Given this list of marker genes PIGM, RFX3, MAU2, AAR2, TRIM32, LYN, FBXL5, NT5E, MCC, TBC1D12, CDIPT, PI15, CLOCK, PRELID3B, SH3BP4, RTKN2, CREB1, UGT1A4, PAPPA, EMP2, MAP4, SKA1, GALNT18, HDAC9, MAFB, HSPE1, TCF7L2, RPS6KA6, NCK1, ADAM28, BBC3, STX18, CREBRF, FLVCR2, C3orf70, CMTM4, GOLPH3L, SYT9, PHIP, SESTD1, RD3L, BARD1, RICTOR, DLX3, NCKAP5, ADAMTS6, SLC5A3, HELB, TREM1, KIF3A, PLPPR4, DMKN, MXD1, DUSP16, FGG (NCBI Gene Id 2266), MAGEA8, ZNF706, MTCL2, RBM12, ZNF566, PABIR1, DIP2B, FAT4, TK2, ZNF699, SERPINB5, C3orf62, RAP1B, ENAH, ARHGEF11, FXYD6, CNOT6, ATP2B2, PPP1R1C, GPATCH2L, KIN, SGO1, SEMA3A, LAMC1, ALK, RIPOR3, H3-3B, RTP4, NEXMIF, A1CF, MAB21L1, NCL, ROCK2, TM9SF3, EVI5, UGT1A3, SNX13, RRAGB, SH3PXD2B, NREP, BCL2L2-PABPN1, MED13L, ADGRL2, UCK2, ARSJ, KLF12, GMFB, SDR16C5, GABRP, ZBTB14, EPHA5, YWHAQ, PARP9, AQR, MAGEA4, NAB1, MMD2, ZNF251, GATAD2B, CDK12, ABCA9 (ATP binding cassette subfamily A member 9), RBMS3, NFYC, CSTF2T, GAPVD1, SH3GLB2, KIF5B, USP37, UBE2H, RBM11, ZNF565, TIMELESS, PCDH19 (protocadherin 19), MOB1B, ALDH6A1, CAP1, SALL4, GRM3, CHST2, UTRN, MBOAT2, ACER3, DLG2, FBXL3 (F-box and leucine rich repeat protein 3), KDM2B (lysine demethylase 2B), SYTL4, HLF, MTX2, UGT1A8, MSI1, PIK3R3, ZBTB34, ZNF704, HOXA7, KLHL13, UNC5C, SSR3, ASH1L, SRR, KCNQ5, UGT1A9, ACO1, RPRD1A (NCBI Gene Id 55197), SLC7A14, LRCH1, CASD1, SRGAP3, LAMP3, NR3C1, TUB, GMCL1, GPR146, CLINT1, KLHL24, AHR, HIC2, SBSPON, NHLH2, TRMT10A, ATG2B, SEZ6, UGT1A6, NFAT5, ADAM22, SLC25A24, PREX1, MOB3B, MACO1, SHISA6, LRP2, SMAD2, SYT1, RFLNB, UBTF, PLCB4, RFPL1, MTFR2, SNX17, GPM6B, TATDN3, IQGAP2, KIF21A, UGT1A7, STEAP4, LRRTM4, UGT1A5, PGAP4, MME, FSTL1, SART3, CDKN1B, STARD13, TSPAN2, ALG6, ENOX1, RAB3GAP2, PAK3, PHF20L1 (PHD finger protein 20 like 1), ZNF148, MFAP1, FAM53A, PTBP3, ZZZ3, ZBTB41, VOPP1, TRPM7, PTPN14, GABRA1, ERLIN2, XPR1, TOX3, UNC79, PRLR, UGT1A10, TAS2R14, FDFT1, ZNF770, PRKACB, KCNA1, SLC30A4, PABPN1, MTO1, FZD6 (frizzled class receptor 6), GTF2H1, DCAF7, PFN2, HTR2B, RABL2A, MRPL43, NAV3, CTNNB1, GABRA6, PPFIA2, CUL4B, AIDA, CP, CELF2, PURA, GFRA1, SMYD2, KLHDC10, MS4A1, ASB7, ZNF750, PHYHIPL, HDAC4, MBNL1, CNBD2, TANC2, UGT1A1, RFPL3, PHF13, SOS1, EDNRB, MMP16, CKAP5 (cytoskeleton associated protein 5), CACNB4, EDIL3, GCH1 (NCBI Gene Id 93984), INO80D, NCEH1, EML4, VAMP3, EPB41L5, GJA9, DPPA4, ACKR3, SPAG1, DDX41, RFPL2, WAC (WW domain containing adaptor with coiled-coil), PLCB2, MGMT, BCHE, here is a description of the gene set: species: Homo sapiens Human Gene Set: MIR4496 from publication Chen Y, Wang X (PMID 31504780) Genes predicted to be targets of miRBase v22 microRNA hsa-miR-4496 in miRDB v6.0 with MirTarget v4 prediction scores > 80 (high confidence targets).